The following is a description of a gene set: Human Gene Set: GOMF_DNA_DIRECTED_DNA_POLYMERASE_ACTIVITY Catalysis of the reaction: deoxynucleoside triphosphate + DNA(n) = diphosphate + DNA(n+1); DNA-template-directed extension of the 3'-end of a DNA strand by one nucleotide at a time. studied in species Homo sapiens, and this is the list of marker genes: POLE, POLG2, CHRAC1, POLN, REV1, POLK, POLL, POLD4, POLE2, POLE4, POLA1, POLM, PRIMPOL, REV3L, POLD1, DNTT, POLB, POLH, POLQ, POLD3, POLI, POLG, POLE3